The following is a description of a gene set: Mouse Gene Set: REACTOME_BETA_OXIDATION_OF_PRISTANOYL_COA studied in species Mus musculus Beta-oxidation of pristanoyl-CoA, and this is the list of marker genes: Acot8, Scp2, Crat, Acox3, Hsd17b4, Acoxl, Amacr, Acox2, Crot